The following is a description of a gene set: Mouse Gene Set: GOBP_PROTEIN_LOCALIZATION_TO_CHROMOSOME Any process in which a protein is transported to, or maintained at, a specific location on a chromosome. species: Mus musculus, and this is the list of marker genes: Brme1, Rpa1, Rb1, Potefam3a, Airn (NCBI Gene Id 72704), Spo11, Pml, Acd (NCBI Gene Id 497652), Ctcfl, Mcm9, Mrnip, Jarid2, Tasor, Snhg15 (NCBI Gene Id 100041286), Daxx, Ankrd66, Brca2, Trp53bp1, Dkc1, Xrcc4, Slf2, H2ax, Vcpip1, Mtbp, Ruvbl2, Rpa2, Zw10, Brd2, Wrap53, Pot1a, Tnks2, Ik, Spdya, Cct3, Cenpa, Cyren, Gnl3, Msh2, Smc5, Nipbl, Cct4, Stag3, Pphln1, Parp3, Potefam3b, Ttk, Tonsl, Cct2, Champ1, Lemd2, Topbp1, Rnf4, Aurkb, Iffo1, Trappc12, Brd3, Lef1, Mms22l, Cct7, Cdk9, Wbp2, Xrcc5, Setd2, Cct5, Nabp2, Cct8, Esco2, Plk1, Gnl3l, Spi1, Mis18a, Vrk1, Spin1 (NCBI Gene Id 218246), Lrwd1, Scml2, Chmp7 (charged multivesicular body protein 7), Macroh2a2, Spidr (NCBI Gene Id 77584), Tert, Carm1, Tpp1, Terf1, Rad17, Mdc1, Bub3, Ctcf, Rhno1, Tex15, Vcp, Esr1, Cdk1, Bub1b, Knl1, H2ac4, Pinx1, Spdl1, Terf2ip, Mir208b, H1f5, Rad21, Kntc1, Zwilch, Ezh2, Sirt6, Tnks (tankyrase, TRF1-interacting ankyrin-related ADP-ribose polymerase), Tinf2, Slf1, Pias4, Cct6a, Wapl, Atr, Terf2, Zmynd8, Aplf, Macroh2a1, Zfp827 (zinc finger protein 827), Parp1, Htatsf1, Haspin, Atrx, Cenpq, Mcm8, Pot1b, Nbn, Tcp1, Rcc2